The following is a description of a gene set: The cell cycle process by which a cell in G1 phase commits to S phase. species: Mus musculus Mouse Gene Set: GOBP_CELL_CYCLE_G1_S_PHASE_TRANSITION, and this is the list of marker genes: Crebbp, Ccnj, Taf10, Ccnb1, Bid (NCBI Gene Id 72579), Arid2 (AT-rich interaction domain 2), Plk2, Dbf4, Trp53, Usp29, Cul4b (NCBI Gene Id 72584), Plrg1 (pleiotropic regulator 1), Smarcd1, Smarcc1, Rfwd3, Myc, Kmt2e, Ccng2, Tcim, Lats1, Cyp1a1, Eif4e, Tcf3 (transcription factor 3), Smarca2, Cdk1, Rps6, Bcl2, Senp2, Inhba, Trex1, Cdkn2c, Rrm2, Ccna1, Mir26b, Gjc2, Adam17, Psme3, Ppp3ca, Cdk6, Rpl17, Dpf1, Rbl1, Ptprv (NCBI Gene Id 64447), Smarca4, Tm4sf5, Ankrd17, E2f3, AY074887, Cdc25a, Plcg2, Tmsb4x, Rcc1, Brd4, Skp2, Plk5, Nasp, Myb, Gpr132, E2f6, Cdkn2a, Ube2e2, Pkd2, Klf4, Tbx1, Npat, Ddx3x (NCBI Gene Id 236681), Hspa8 (NCBI Gene Id 69197), Cdk3, Mnat1, Sox2, Bmyc, Ctdsp1, Cdk4, Sass6, Cdk2ap2, Cacnb4, Pim2 (NCBI Gene Id 65950), Cdk2, Myo16, Stxbp4 (NCBI Gene Id 320264), Cdkn1b, Acvr1b, Mepce, Phf10, Csf1r, E2f4, Ccnd1, Smarce1, Gigyf2, Ccnf, Ccnjl, Slfn1, Ccna2, Usp37, Actl6a, Rgcc, Rbbp8, Btn2a2, Camk2a (calcium/calmodulin-dependent protein kinase II alpha), Ambra1, Cdk7, Ccnb2, Apex1, Ddr2, Mtbp, Fhl1, Eif4g1, Ccnd2, Rptor (regulatory associated protein of MTOR, complex 1), Eif4ebp1, Ppp6c, Cdc73, Camk2b, Bcl7c, E2f1 (E2F transcription factor 1), Fbxo31, Rdx, Rps6kb1, Ccng1, Susd2 (NCBI Gene Id 71733), Ccni, Phb2, Pbrm1, Ccno, Ino80, Anxa1, Tbx2, Camk2g, Cdkn2d, Smarcd2, Ccne1, Bcl7b, Mblac1, Trp63, Ctdspl, E2f5, Dcun1d3, Trim71, Egfr, Lsm10, Prmt2, Ppp2r3d, Aif1, Pagr1a, Apbb1, Arid1a, Phf8, Kank2, Appl1, Actb, Psme2, Plk3, Acvr1, Pkp3, Akt1, Tfdp1, Hacd1, Pole (NCBI Gene Id 18973), Prkdc, Haspin, Wac, Id2, Map3k11, Trim39, Mir26a-2, Ppp2ca, Cacul1, Stox1, Rps27l, Mettl13, Ptpn6, Dact1, Ccnb3, Iqgap3, Sde2, Hyal1, Jade1, Appl2, Cul4a, Ccnh (cyclin H), Smarcc2, Cpsf3, Cables1, Smarcb1, Gli1, Ccl12, Paf1, Klf11, Gpr15lg, Gpnmb, Lats2, Dpf2, Stil, Larp7, Kcna5, Rhou, Cenpj, Usp26, Cirbp, Fam83d, D1Pas1, Hinfp, Zc3h12d, Rrm1, Pdpn, Tert, Dgkz (NCBI Gene Id 352984), Mlf1, Zfp655, Ecd, Smarcd3 (SWI/SNF related, matrix associated, actin dependent regulator of chromatin, subfamily d, member 3), Id4 (NCBI Gene Id 15904), Itgb1, Ccne2, Spdya, Pias1, Rassf1, Brd7, Nfatc1, Crlf3, Men1, Crnn, Fam107a, E2f7, Rb1, Rbl2, Tjp3, Ctdsp2, Bcl7a, Rpa2, Gas1, Mn1, Fbxo7, Pten, Kif14, Plpp2, Fgf10, Actl6b, Mir26a-1, Pkd1, Apc, Dlg1, Camk2d, Ccnd3, Plcb1, Ezh2, Dpf3, Tcf19, Cdkn1a, Cdkn2b, Adamts1, Anp32b, Psme1, Atp2b4, Mdm2, Lsm11